The following is a description of a gene set: species: Homo sapiens A homeostatic process involved in the maintenance of a steady state level of potassium ions within a cell. Human Gene Set: GOBP_INTRACELLULAR_POTASSIUM_ION_HOMEOSTASIS, and this is the list of marker genes: ATP12A, ATP4B, ATP1B3, PRKACA, ATP1A4, YWHAE, FXYD2, KCNMA1, ATP1B2, ATP1A2, ATP1B1, ATP4A, SLC12A2, KCNJ2, ATP1A1, KCTD7, ATP1A3